The following is a description of a gene set: Human Gene Set: GAVISH_3CA_METAPROGRAM_EPITHELIAL_CELL_CYCLE species: Homo sapiens Genes upregulated in subsets of cells of a given type within various tumors In this study, an extensive analysis was conducted to define meta-programs (MPs) capturing intra-tumor heterogeneity across a spectrum of tumor types. The approach utilized non-negative matrix factorization (NMF) to analyze each cell type separately within individual tumor samples. This involved the analysis of malignant cells, macrophages, fibroblasts, endothelial cells, epithelial cells, T-cells, and B-cells. NMF was executed with varying parameter values (K=4, 5, 6, 7, 8, 9), thereby generating 39 programs for each cell type per sample. Each NMF program was summarized by the top genes based on NMF coefficients.\nRobust MPs were then delineated for each cell type using a set of stringent criteria, including recurrence within the same tumor, similarity to programs in other tumors, and non-redundancy within a tumor. Subsequently, these robust NMF programs were clustered (per cell type) based on Jaccard similarity, leading to the identification of MPs associated with each cell type.\nTo enhance the quality of the MPs, a refinement steps were undertaken, involving the removal of MPs suspected of reflecting low-quality data (with an overrepresentation of ribosomal proteins or mitochondrial-encoded genes), single-study inclusion, or similarity to miss-annotated cell types. from publication Gavish A, Tyler M, Greenwald AC, Hoefflin R, Simkin D, Tschernichovsky R, Galili Darnell N, Somech E, Barbolin C, Antman T, Kovarsky D, Barrett T, Gonzalez Castro LN, Halder D, Chanoch-Myers R, Laffy J, Mints M, Wider A, Tal R, Spitzer A, Hara T, Raitses-Gurevich M, Stossel C, Golan T, Tirosh A, Suvà ML, Puram SV, Tirosh I (PMID 37258682), and this is the list of marker genes: ANP32E, STMN1, CDC20, ASPM, RRM2, KIF20B, DEK, DTYMK, H2AZ1, TUBB, CCDC34 (NCBI Gene Id 91057), CENPW, CDK1, KPNA2 (karyopherin subunit alpha 2), CDKN3, SMC2 (NCBI Gene Id 10592), TMPO, H4C3, MAD2L1, UBE2C, TUBA1B, HMGB3, CENPU, CKS1B, RPA3, DUT, BIRC5, PRC1, CCNB2, TPX2, TUBB4B, NUSAP1, CENPF, HMGN2, UBE2T, PTTG1, TYMS, SMC4, TK1, PCNA, NUDT1, HMGB2, MKI67, ZWINT, TOP2A, CKS2, PCLAF, CCNB1, UBE2S (NCBI Gene Id 27338), H2AZ2